The following is a description of a gene set: species: Mus musculus A phospholipase C-activating receptor G protein-coupled receptor signaling pathway initiated by serotonin binding to its receptor on the surface of a target cell, and ending with the regulation of a downstream cellular process, e.g. transcription. Mouse Gene Set: GOBP_PHOSPHOLIPASE_C_ACTIVATING_SEROTONIN_RECEPTOR_SIGNALING_PATHWAY, and this is the list of marker genes: Htr2c, Plcb3, Htr2b, Htr2a, Htr1b